Given this list of marker genes Pold2, Cdc5lrt6, Etaa1, Rpa1, Baz1b, Cdc5lrt1, Ercc5, Cdc5lrt4, Wdhd1, Parp1, Pold3, Rpa3, Trex1, Bcas2, Prpf19, Zmiz2 (zinc finger, MIZ-type containing 2), Plrg1, Smarcal1, Mus81, Helb, Zranb3, Xpa, Pcna, Cdc5lrt7, Prim2, Eme2, Cdc5l, Smarcad1, Prim1, Eme1, Carm1 (coactivator-associated arginine methyltransferase 1), Tonsl, Pold4, Smarca5, Cdc5lrt8, E2f6, Tipin, Pola2, Pold1, Pola1, Mms22l, Rpa2, Timeless, Cdc5lrt5, Cdc5lrt10, Mcm10, Cdc5lrt9, here is a description of the gene set: studied in species Mus musculus The Y-shaped region of a nuclear replicating DNA molecule, resulting from the separation of the DNA strands and in which the synthesis of new strands takes place. Also includes associated protein complexes. Mouse Gene Set: GOCC_NUCLEAR_REPLICATION_FORK